Given this list of marker genes Fbxl4, Parl, Htra2, Ube2a, Mul1, Usp30, Rnf41, Slc25a4, Irgm2, Nod2, Hk2, Adcy10, Pink1, Hdac6, Tomm7, Stub1, Gba1, Pptc7, Slc25a5, Irgm1, Eif2ak1, Cttn, Huwe1, Atp5if1, Vdac1, Cers1, Prkn, Bnip3l, Ambra1, Clec16a, Bnip3, Htt, Fbxw7, Vps13d, Dnm1l, Tigar, Gsk3a, Dele1, Vps13c, Cdc37, Trp53, Fkbp8, Tspo, Igtp, Fbxo7, Srebf1, here is a description of the gene set: Any process that modulates the frequency, rate or extent of mitochondrion degradation by an autophagic process. Mouse Gene Set: GOBP_REGULATION_OF_AUTOPHAGY_OF_MITOCHONDRION studied in species Mus musculus